Given this list of marker genes DAAM1, PTGIR, WHAMMP3, SCN1B, RAP1B, ITM2B, AQP10, INF2, CFAP161, SDC4, TMBIM1, AKIRIN2, CLDN5, ACTR3B, ZNF367, RASA3, YWHAH, MMRN1, GPX1, TAL1, PPP3R1, H2AC6, CD226, LINC00938, CARD19, TAGLN2, FSTL1, GNAS, CIMAP3, CAVIN2, HBA1, CASP3, CALM1, ARPC4, PPM1A, LGALS12, TPM3, MORN2 (NCBI Gene Id 732175), GGTA1, PIP, TNS1, ARF4, PRDX5, MTFR1L, CLIC4, PCYT1B, LINC02915 (long intergenic non-protein coding RNA 2915), PTPN18, SEPTIN4, GRHL1, AGR2, ARHGAP45 (Rho GTPase activating protein 45), VAMP7, PIK3CB, GNAZ (NCBI Gene Id 2781), MKRN1, GP9, MOB1A, CCND3 (NCBI Gene Id 896), SH3TC2, LAMTOR1, CTTN (NCBI Gene Id 2017), HIGD1A, YIF1B, NUTF2, MTURN, AMD1, ABCC3, PVALB, PYGL, CABP5, BCL2L1, CCNG1, C2orf88, AGR3, MAP3K7CL, NEXN, RGS10 (regulator of G protein signaling 10), IGFBP2, SLA2, CFAP45, HPCAL1, PPDPF, PROS1, DAB2, CXCR2P1, PPBP, FLNA, SUSD3, TSPAN9, GATA1, FKBP8, TSPAN33, WDR11-DT, RAB11A, MS4A8, HACD4, FRMD4B, LIMS1, PLEK (NCBI Gene Id 5341), MIR4435-2HG, CETN2, RAB4A, CLEC1B, H2BC9, VIM-AS1, RGS6, ARRB1, H2BC21, TMEM91, TM6SF1, MYL12A, THRB-AS2, CDKN2D, UBE2E3, ZNF542P, RHOBTB1, WWC1, CAPSL, TSPAN1, ABLIM3, ZMYND10, CYTOR (cytoskeleton regulator RNA), FSTL4, SWI5, KIFC3, SERPINE2, INAFM2, SMOX, INKA2, SPHK1, TNFSF4, IGF1R, ITGB3, ABCB6, PAIP2, SMIM3, HMG20B, TPST2, TFPI, VAPA, ANKRD9, STRN4, SH3BGRL2, FRMD3, IRX3, BBC3, HLA-E (major histocompatibility complex, class I, E), TRAPPC3L, PTPRJ, MAP2K3, SCFD2, KRT8, PPP1R14A, MYLK, H3C10, CMTM6, LY6G5C, ENKUR, TCEAL9, PDLIM4, RAB8A, GAPDH, RSU1, PEAR1, NDUFS5, TREML1, FKBP1A, NDUFA5, WBP2, TACSTD2, PCP2, MAFG, CAMTA1, PSTPIP2, RTN3, RARG, SLBP, AP2S1, GFI1B, ARMC3, GRAP2, EMC3, SLC40A1, MYH9, CMIP, ANO6, CIBAR2, UBE2O, SNTN, RAB6B, TALDO1, BNIP3, MOB3C, BEND2, RILPL1, TGFB1I1, CMPK1, FHL1, UNC13D, RAP2B (RAP2B, member of RAS oncogene family), N4BP2L1, ACTB, DHRS3, MGLL, ARPC1B, SNCA, PLA2G12A, ARHGAP6, CD151, GSTA1, TBXA2R, ARHGAP21, CD36, FAM30A, PTGS1, IGF2BP3, RAB37, KIF2A, EIF2AK1, CDKN1A, BRD3, TMEM140, PRKCD, GSN, CORO1C, UXS1, TSC22D1, CCL5, HBB, PDLIM7, MFSD1, GET1, HHEX, TUBA1C, TSC22D4, SNAP23, CMTM5, CTSA, TMEM50A, CAPS, OAZ1, ODC1, CD47, MPST, SELP, MPIG6B, ATP2A3, ATP6V0E1, TPTEP1, RBX1, BEX3, RHEB, NSMCE3, H1-2, SQSTM1, ARF3, NOMO1, PIP4P2, IRAK2, PDCD10, CALD1, ASAP1, C19orf33, DMTN, STON2, TJP2, ASAP2, H1-0, ZNF185, CYREN, FERMT3, PGRMC1, GABARAPL2, MYL9, HDAC5, BAIAP2, PNMA1 (PNMA family member 1), FAM81B, RUFY1, AFAP1L2, GRTP1, DOK1, PEDS1, HK1, ATP9A, CAV2, CYB5A, H2AJ, MISP3, CLIC1, PDGFA, TMEM17, PIGR, EIF4G2, ELF3, MYL6, LEPROT, TMCC2, FAXDC2, MYZAP, TPM1, CERS2, BMP6, PKM, SRSF8, ENDOD1, GTPBP2, RAC1, SSBP2, TUBA8, C1orf198, CCDC85B, MDM1, CFAP144, SPNS1, MICU1, MEIS1, SCGB1C1, LDLRAP1, NRGN, CYP4B1, SPINT2, GRK5, GMPR, CIMIP1, PRDX6, NAP1L1, NFE2, TMEM64, MPP1, MEPCE, MPL, AIG1, LINC01089, LY6G6F, ZGLP1, LYL1, C20orf96, DNAJB6, RASGRP2, F2R, FXYD3, BIN2, RDH11, ZNF271P, HEMGN, LRRIQ1, ITGB1, CCDC78, PTK2, TDRP, GADD45A, ZFYVE21, ARPC5, UBXN6, RAB27B, RAB32, ADIPOR1, FOLR1, TBC1D20, WRNIP1, LTBP1, TPM4, CXCL17, MAPRE2, EGLN3, RABGAP1L, DOK2, CD27-AS1, PDLIM1, AGPAT1, TRAPPC5, SPMIP6 (sperm microtubule inner protein 6), H2BC12, TACC3, PARVB, P2RY12, SLC6A4, CALM3, HBQ1, TWSG1, SLC44A4, YWHAZ, KRT18, CNST, SIAE, ZYX, PRR7, SLC34A2, SPARC, PRKAR2B, NT5C3A, ROPN1L, TST, UBA7, CLDN3, NDUFA6, LYPLAL1-AS1, UBXN11, SLPI, PDZK1IP1, RSPH9, SENCR (smooth muscle and endothelial cell enriched migration/differentiation-associated lncRNA), PF4V1, CP, UBAC2, MARCHF2, ELOVL7, RGS18, DIAPH1, ISCA1, FAM110A, SEC14L1, SCGB1C2, MFAP3L, ABCC4, H2BC5, INSIG1, USF2, DPCD, HGD, AP1M2 (adaptor related protein complex 1 subunit mu 2), FOXJ1, ARF1, RIOK3, TUBB1, GNB5, MOB1B, CENPT, NORAD, MYCT1, PIP4K2A (NCBI Gene Id 5305), TNNC2, TMC5, EPOR, KIAA0513, DYNLRB2, ABHD16A, TMSB4X, ARG2, MAX, LGALSL, ACVR1, RPL23AP7, TLN1, CCDC103, RPA1, HEXIM2, MIR6843, CFAP276, CAPN1 (NCBI Gene Id 823), CFAP90, LYPLAL1, MLH3, F2RL3, MINDY1, PTCRA, BICD2, WFDC2, SMIM22, AP2M1, EPCAM, RBBP6, PCSK6, ZCCHC17, SMIM5, UBL4A, CYTH2, SLC39A3, H3P6, RTN4, TPPP3, DAPP1, CHMP6, ITGB5, XPNPEP1, CD9, RNF11, NCK1-DT, GUCY1A1, PRKAR1B, NAT8B, F11R, MACIR, TMEM219, SH3BGRL, CDK2AP1, PBX1, SYMPK, PARD3, LINC00853, PIERCE1, OSBPL6, PACSIN2, GP6, NCK2, PRUNE1, PDE5A (NCBI Gene Id 8654), TUBB4B, CLU, FANK1, MMD, GPX4, KRT7 (NCBI Gene Id 3855), CYB5R3, ALOX12, STX11, STOM, APP, LINC01011, ETFA, CA2 (carbonic anhydrase 2), MCUR1, R3HDM4, CYB5R1, NDUFAF3, NENF, PF4, DNM3, IFRD1, PSCA, TSPOAP1-AS1, RSPH1, TRIM58, GUCY1B1, WIPI1, UQCRH, CLDN4 (NCBI Gene Id 1364), H2BC8, C12orf76 (NCBI Gene Id 400073), SH3BGRL3, LAT (linker for activation of T cells), TLK1, WHAMMP2, TGFB1, HMGB1, SEMA4D, GP1BA, INKA1, DCLRE1A, SPOCD1, ICAM2, PTTG1IP, WDR1 (NCBI Gene Id 9948), H2AC8 (NCBI Gene Id 3012), SIAH2, GSTO1, NCKAP1, ANAPC5, JAM3, YPEL5, ECRG4, PDGFA-DT, BBLN, CLTA, DERA, TSPAN18, AHCTF1, TUBA4A, MAD2L1BP, DUSP22, KRT19, DYNLL1, CAPZA2, SRC, ILK, SYTL4, RBPMS2, OST4, RIT1, TAOK3, EIF4E, VCL, VDAC3, STXBP2, ACTN1 (actinin alpha 1), TM2D2 (TM2 domain containing 2), GSTP1, ESAM, CAP1, ABI1, ITGA2B, LPAR5, GAS2L1, CTDSPL, ARHGAP18, NCOA4, SSX2IP, SNN, GNG11, KLF5, HOATZ (HOATZ cilia and flagella associated protein), TMEM40, RAB10, MSANTD3, ACRBP, ACSBG1, BLOC1S6, PLEKHO1, PARK7, NT5M, F13A1, FHL2, LCN2, SAT1, here is a description of the gene set: Human Gene Set: TRAVAGLINI_LUNG_PLATELET_MEGAKARYOCYTE_CELL from publication Travaglini KJ, Nabhan AN, Penland L, Sinha R, Gillich A, Sit RV, Chang S, Conley SD, Mori Y, Seita J, Berry GJ, Shrager JB, Metzger RJ, Kuo CS, Neff N, Weissman IL, Quake SR, Krasnow MA (PMID 33208946) species: Homo sapiens